Given this list of marker genes POLRMT, LIG3, SSBP1, TOP3A (NCBI Gene Id 7156), POLG, TWNK, RNASEH1, MGME1, POLG2, EXOG, here is a description of the gene set: The human mitochondrial genome is a circular double-stranded DNA of 16569 bp that encodes 2 rRNAs, 22 tRNAs, and 13 proteins. Based on density in a denaturing cesium chloride gradient, a heavy (H) strand and a light (L) strand are distinguishable. Two basic mechanisms of mitochondrial DNA replication have been proposed: (1) strand-asynchronous DNA replication (also called strand-displacement DNA replication), in which initiation of H strand synthesis significantly precedes initiation of L strand synthesis and each initiation is primed at a specific origin, and (2) strand-synchronous DNA replication, also called strand-coupled DNA replication, in which initiations of H strand synthesis and L strand synthesis occur concurrently and are primed by short RNA primers distributed through the genome. Both types of synthesis may occur in mitochondria and the choice of synthesis type may depend on the abundance of the DNA helicase TWINKLE (TWNK, PEO1) and RNA transcripts. The strand-asynchronous model has existed longer and has been more completely characterized. There is also some question of the evidence supporting the existence of RNA primers throughout the genome.<br>In the strand-asynchronous mechanism, the H strand is polymerized first from an origin of replication (OriH) located near the L strand promoter (LSP), which initiates transcription of the L strand as a template and a RNA corresponding to the sequence of the H strand as a product. The transcription elongation factor TEFM acts as a switch between transcription of the entire L strand and synthesis of a short primer for DNA replication. The mitochondrial RNA polymerase POLRMT at LSP initiates synthesis of the H strand by polymerizing a short RNA of about 120 nucleotides that extends from the LSP to conserved sequence block 2 (CSB2). The 3' end of the RNA is located in a G-quadruplex secondary structure that renders the 3' hydroxyl inaccessible for priming DNA synthesis and that creates a persistent R loop. RNASEH1 cleaves the RNA in the RNA-DNA duplex and creates accessible 3' hydroxyl groups.<br>The DNA helicase TWINKLE (TWNK, PEO1) and the mitochondrial DNA polymerase POLgamma, a complex comprising one subunit of POLG and two subunits of POLG2 (POLG:POLG2), bind the OriH region. TWNK binds as an open hexameric ring that closes around the DNA and hydrolyzes ATP to dissociate double-stranded DNA ahead of POLgamma, which uses the 3' hydroxyl groups of the RNA at OriH to begin polymerizing the nascent H strand. As polymerization proceeds, the parental H strand is displaced and bound by single strand binding protein 1 (SSBP1) (Miralles Fusté et al. 2014, Kaur et al. 2018, Plaza-G A et al. 2023). There is also evidence of long RNAs binding the displaced H strand (the "bootlace" model, Reyes et al. 2013).<br>Synthesis of the H strand continues until POLgamma passes the origin of L strand replication (OriL) about two thirds of the way around the 16569 bp genome. OriL becomes single-stranded and assumes a secondary loop structure that binds POLRMT, which synthesizes a short RNA that acts as a primer for DNA synthesis. Significantly, OriL is required for mitochondrial maintenance in mice, evidence that the strand-asynchronous replication mechanism is essential.<br>As POLgamma nears completion of the H and L strands, it migrates around the circular genome and reaches the 5' ends of the RNA primers. RNASEH1 cleaves all but two ribonucleotides from the primers in the nascent H and L strands. Subsequent processing of the H and L strands differs slightly. A flap structure appears to be created by displacement at the 5' end of the H strand and the flap is removed by MGME1. A similar flap structure at the 5' end of the L strand is removed by another nuclease that, based on in vitro evidence, may be EXOG.<br>The remaining gaps in the H and L strands are ligated by the mitochondrial isoform of ligase III (LIG3-1). The resulting two double stranded mitochondrial genomes remain catenated by single strands which are resolved by topoisomerase 3A (TOP3A). part of: DNA Replication Reactome Pathway: Strand-asynchronous mitochondrial DNA replication studied in species Homo sapiens